The following is a description of a gene set: Mouse Gene Set: MP_INCREASED_SQUAMOUS_CELL_CARCINOMA_INCIDENCE from publication Motenko H, Neuhauser SB, O'Keefe M, Richardson JE (PMID 26092688) studied in species Mus musculus Mouse genes annotated to increased squamous cell carcinoma incidence (MP:0004207) retrieved from the Mouse Genome Informatics database via MouseMine, and this is the list of marker genes: Trp53, Pten, Ssbp2, Cebpa, Met (met proto-oncogene), Cdkn1a, Atp2a2, Nkx2-9, Kras, Taf4, Atp2c1, Ptgs2, Pold1, Plk1, Mlh1, Msh2, Dek, Trim62, Otulin (OTU deubiquitinase with linear linkage specificity), Aurka, Brca1, Polh, Stk11, Trp63, Ddb2, Cdkn2a, Trp53bp2, Akt1, Bap1, Tiam1, Sfn, Tusc2, Hic1